The following is a description of a gene set: species: Homo sapiens Precocious atherosclerosis Human Gene Set: HP_PRECOCIOUS_ATHEROSCLEROSIS, and this is the list of marker genes: LDLRAP1, LDLR, APOA5, APOB, ABCG5, LPL, PCSK9, CYP27A1, ABCG8, TNXB, LMNA